The following is a description of a gene set: from publication Chen Y, Wang X (PMID 31504780) species: Mus musculus Genes predicted to be targets of miRBase v22 microRNA mmu_miR_6943_5p in miRDB v6.0 with MirTarget v4 prediction scores > 80 (high confidence targets). Mouse Gene Set: MIR_6943_5P, and this is the list of marker genes: Gata4, Cyp1a2 (cytochrome P450, family 1, subfamily a, polypeptide 2), Tspan18 (tetraspanin 18), Frmd6, Fibcd1, Zdhhc20, Agap1, Mpig6b, Lpcat3, Atp4a, Tmem250 (NCBI Gene Id 99019), Rab44, Tgoln1, Dagla, Igfbp5, Vwa3a, Muc15, Mxra7, Zfhx2, Zfp579, Cpne5, Aif1l, Fbxo11, Usp4, Cfl1, Ttbk1, Pnkd, Nfix, Ankrd52, Hif3a, Mmp28, Cmtr1, Cdc25a, Plxna4, Celf2, Nfam1, Nexmif, Myo1c, Slc18b1, Map3k12, Fgd2, Txnip, Rho, Cltb, Rbm43 (RNA binding motif protein 43), Eif4g2, Mark2, St3gal2, Poc1b (NCBI Gene Id 71261), Rusf1 (RUS family member 1), Zfp616 (zinc finger protein 616), Fubp3, Tex16, Abhd2, Klhl18, Mlxip, Prss32, Exosc2, Acnat2, Vdr, Phf8, Rasl10b, Senp2, Pou2f1, Tm2d2, Trim28, R3hdm1 (NCBI Gene Id 226412), Wdr64, Chit1, Atp10b, Rfng (NCBI Gene Id 19719), Dlk1, Tubg2, Rcbtb2, Pip4k2b, P2rx3, Dnajb5